Given this list of marker genes JUNB, PCSK1N, TRO, GH1, CPE, EGR1, VEGFD, RIMS3, TSHB, SYT1, CHGA, SYT4, FOS, SYN2, ECE1, CGA, STXBP1, BTG1, EXOC8, CISH, SNAP25, CABLES1, CPLX2, ESM1, POLR3D, PRL, CHGB, CCNB2, PCLO (NCBI Gene Id 56630), GADD45A, RIMS2, DLL3, LHB, PCSK2, CHST8, EGR2, ATF5, here is a description of the gene set: species: Mus musculus Human Gene Set: WANG_LSD1_TARGETS_DN from publication Wang J, Scully K, Zhu X, Cai L, Zhang J, Prefontaine GG, Krones A, Ohgi KA, Zhu P, Garcia-Bassets I, Liu F, Taylor H, Lozach J, Jayes FL, Korach KS, Glass CK, Fu XD, Rosenfeld MG (PMID 17392792) Genes down-regulated after Cre-lox knockout of LSD1 in pituitary. Precise control of transcriptional programmes underlying metazoan development is modulated by enzymatically active co-regulatory complexes, coupled with epigenetic strategies. One thing that remains unclear is how specific members of histone modification enzyme families, such as histone methyltransferases and demethylases, are used in vivo to simultaneously orchestrate distinct developmental gene activation and repression programmes. Here, we report that the histone lysine demethylase, LSD1--a component of the CoREST-CtBP co-repressor complex--is required for late cell-lineage determination and differentiation during pituitary organogenesis. LSD1 seems to act primarily on target gene activation programmes, as well as in gene repression programmes, on the basis of recruitment of distinct LSD1-containing co-activator or co-repressor complexes. LSD1-dependent gene repression programmes can be extended late in development with the induced expression of ZEB1, a Krüppel-like repressor that can act as a molecular beacon for recruitment of the LSD1-containing CoREST-CtBP co-repressor complex, causing repression of an additional cohort of genes, such as Gh, which previously required LSD1 for activation. These findings suggest that temporal patterns of expression of specific components of LSD1 complexes modulate gene regulatory programmes in many mammalian organs.